Given this list of marker genes AKT2, MTOR, PKP1, METTL3, YTHDF2, NCK1, SH3BGRL, here is a description of the gene set: Human Gene Set: GOBP_POSITIVE_REGULATION_OF_CYTOPLASMIC_TRANSLATIONAL_INITIATION studied in species Homo sapiens Any process that activates or increases the frequency, rate or extent of cytoplasmic translational initiation.